Given this list of marker genes ACAT1, TSPAN3, SRSF7, BMI1, HEXB, SLC39A6, BCL2, DYNLT3, RHEBP1, IGF1, CAV1, ATOX1, BMP6, PECAM1, ITGA4, JAG1, FHL1, DUSP5, ARPC1A, XK, CAV2, AMPD1, CAPN2, SELPLG, P4HA1, S100A6, PIP5K1B, EMP3, MCFD2, PPT1, PAM, HDLBP, CCR2, here is a description of the gene set: from publication Zhan F, Tian E, Bumm K, Smith R, Barlogie B, Shaughnessy J Jr (PMID 12393520) species: Homo sapiens To identify genes linked to normal plasma cell (PC) differentiation and to classify multiple myeloma (MM) with respect to the expression patterns of these genes, we analyzed global mRNA expression in CD19-enriched B cells (BCs) from 7 tonsils, CD138-enriched PCs from 11 tonsils, 31 normal bone marrow samples, and 74 MM bone marrow samples using microarrays interrogating genes. Hierarchical clustering analyses with genes clearly segregated the 4 cell types, and chi-square and Wilcoxin rank sum tests (P <.0005) identified 359 and 500 previously defined and novel genes that distinguish tonsil BCs from tonsil PCs (early differentiation genes), and tonsil PCs from bone marrow PCs (late differentiation genes), respectively. MM as a whole was found to have dramatically variable expression of EDGs and LDGs, and one-way analysis of variance (ANOVA) was used to identify the most variable EDGs (vEDGs) and LDGs (v1LDG and v2LDG). Hierarchical cluster analysis with these genes revealed that previously defined MM gene expression subgroups (MM1-MM4) could be linked to one of the 3 normal cell types. Clustering with 30 vEDGs revealed that 13 of 18 MM4 cases clustered with tonsil BCs (P =.000 05), whereas 14 of 15 MM3 cases clustered with tonsil PCs when using 50 v1LDG (P =.000 008), and 14 of 20 MM2 cases clustered with bone marrow PCs when using 50 v2LDG (P =.000 09). MM1 showed no significant linkage with normal cell types studied. Thus, genes whose expression is linked to distinct transitions in late-stage B-cell differentiation can be used to classify MM. B lymphocyte late differentiation genes (LDG): top genes up-regulated in plasma cells from tonsils (TPC) compared to those from bone marrow (BPC). Human Gene Set: ZHAN_LATE_DIFFERENTIATION_GENES_UP